The following is a description of a gene set: Any process that modulates the frequency, rate or extent of embryonic development. studied in species Mus musculus Mouse Gene Set: GOBP_REGULATION_OF_EMBRYONIC_DEVELOPMENT, and this is the list of marker genes: Uchl5, Insr, Wdpcp, Ino80b, Wnt2b, Mcrs1, Pafah1b1, Trip12, Bag6, Ehmt1, Nipbl, Hspa5 (NCBI Gene Id 99198), Hesx1, Actl6a, Kat14, Lhx1, Nfrkb, Nkx6-3, Rab14, B4galt5, Dll1, Sfrp2, Phldb2, Sox17, Ino80d, Tgif2, Tfpt, Ino80c, Utp25, Cfl1, Khdc3, Nlrp5, Msx1, Hes1, Yy1, Tada2a, Clasp1, Mbip, Wnt3a, Tenm4, Poglut1, Phlda2, Tada3, Lama3, Rack1, Sgf29, Jag1 (jagged 1), Ino80, Tdg, Rbm19, Tgif1, Crb2, Scx, Ruvbl1, Nodal, Tle6, Nlrp4f, Ctnnb1 (NCBI Gene Id 12387), Dhx36, Septin7, Lama2, Kat2b, Racgap1, Hnf4a, Wnt4, Kat2a, Ruvbl2, Foxa2, Wnt2, Ccsap, Osr1, Actr5 (NCBI Gene Id 98810), Amot, Noct, Dr1, Lama5, Wdr5, Zbed3, Zzz3, Phldb1, Nfe2l2, Notch1, Osr2, Lama1, Dag1, Otx2, Plcb1, Actr8, Yeats2, Clasp2, Nr2c2, Wnt1, Lama4, Rps6ka6